The following is a description of a gene set: species: Homo sapiens MITF-M-dependent gene expression Human Gene Set: REACTOME_MITF_M_DEPENDENT_GENE_EXPRESSION, and this is the list of marker genes: TNRC6A, MYO5A, ACTB, CDH1, BCL2A1, SMARCC1, SOX10, GMPR, ATP6V0C, TYRP1, ATP6V0A1, ATP6V0D1, ITGA2, AGO3, TCF7, DPF1, ATP6V1E1, TCF7L2, USP46, ATP6V1F, SERPINE1, BCL7C, MCM2, PMEL, ATP6V0E2, CDH2, LIG1, ARID1A, TYR, MLANA, MITF, SOX2, GXYLT2, EDIL3, AGO4, DPF2, TERT, BIRC7, BCL2, TCF7L1, DPF3, SMARCC2, MLPH, SMARCD2 (NCBI Gene Id 6603), STT3B, ACTL6A, PXDN, DIAPH1, TRPM1, ATP6V1D, MIR211, SIRT1, SMARCA4, MCM5, GPR143, CCND1, SMARCD3, DICER1, HINT1, CDC25B, CREB1, CEACAM1, MYRIP, PPARGC1A, HDAC1, ATP6V1A, POU3F2, ATP6V1H, TBX2, ATP6AP2, CDKN2A, ARID1B, ATP6V1C1, SMARCD1, TNRC6C, DCT, CTNNB1, BCL7B, SS18L1, SYTL2, SMARCA2, SS18, TNRC6B, CDKN1A, AGO1, ATP6V1B2, AGO2, BRCA1, CDK2, ATP6V0E1, PXN, ATP6V0B, LEF1, AKT2, IRF4, USF1, ZEB1, SMARCB1, ASAH1, MET, TFAP2A, CCNB1, MOV10, BCL7A, MAPK14, SIN3A, ATP6V1G1, RAB27A, PLK1, SMARCE1